The following is a description of a gene set: studied in species Homo sapiens from publication Gao S, Yan L, Wang R, Li J, Yong J, Zhou X, Wei Y, Wu X, Wang X, Fan X, Yan J, Zhi X, Gao Y, Guo H, Jin X, Wang W, Mao Y, Wang F, Wen L, Fu W, Ge H, Qiao J, Tang F (PMID 29802404) Human Gene Set: GAO_LARGE_INTESTINE_24W_C7_GOBLET_PROGENITOR, and this is the list of marker genes: C16orf87, TSPAN15, FOXA3, WFDC2, CHST5, SPINK4, ELAPOR1, SLC39A7, CHKB, ICA1, ZG16B, ATP6V1H, GALNT5, PURA, REG4, ARL14, GPRIN2, NFX1